The following is a description of a gene set: studied in species Mus musculus Mouse Gene Set: GOBP_L_GLUTAMATE_TRANSMEMBRANE_TRANSPORT The directed movement of L-glutamate across a membrane by means of some agent such as a transporter or a pore., and this is the list of marker genes: Slc1a3, Arhgef11, Slc17a6, Ttyh2 (NCBI Gene Id 68535), Septin2, Slc7a13, Slc38a6, Grm1, Slc1a4, Ttyh3, Itgb1, Slc25a12 (solute carrier family 25 (mitochondrial carrier, Aralar), member 12), Kcnj10, Epm2a, Slc25a22, Slc1a6, Per2 (period circadian clock 2), Slc1a1, Slc25a18, Psen1, Slc1a7, Slc1a2, Tnf, Ttyh1, Ntsr1, Cln8, Slc3a1, Arl6ip1, Slc17a8 (solute carrier family 17 (sodium-dependent inorganic phosphate cotransporter), member 8), Slc17a7, Slc7a11 (solute carrier family 7 (cationic amino acid transporter, y+ system), member 11), Grik1, Slc25a13, Arl6ip5